The following is a description of a gene set: Human Gene Set: GOBP_MITOCHONDRIAL_PROTEIN_PROCESSING studied in species Homo sapiens The peptide cleavage of mitochondrial proteins, including cleavage contributing to their import., and this is the list of marker genes: AFG3L2, ATP23, PMPCB, IMMP1L, MIPEP, LRRK2, SPG7, STOML2, SIRT4, PMPCA, YME1L1, IMMP2L, OMA1